Given this list of marker genes Flvcr1, Flvcr2, Pgrmc2, Slc48a1, Abcb6, Slc46a1, Abcc5, Hpx, here is a description of the gene set: species: Mus musculus Enables the transfer of heme from one side of a membrane to the other. Mouse Gene Set: GOMF_HEME_TRANSMEMBRANE_TRANSPORTER_ACTIVITY